Given this list of marker genes PIGG, PIGM, PIGF, PIGH, PIGP, PIGY, PIGL, PIGV, PIGX, PIGA, PIGQ, PIGW, PIGN, PIGB, PIGO, DPM2, PIGC, PIGZ, here is a description of the gene set: Glycosylphosphatidyl inositol (GPI) acts as a membrane anchor for many cell surface proteins. GPI is synthesized in the endoplasmic reticulum. In humans, a single pathway consisting of nine reactions appears to be responsible for the synthesis of the major GPI species involved in membrane protein anchoring. This pathway is shown in the figure. Two additional reactions, not shown, allow the synthesis of variant forms of GPI, one with an additional mannose residue and one with an additional ethanolamine. These variant GPI molecules may be used for tissue-specific protein modifications, or may function independently.<p>The steps of GPI synthesis were first identified by isolating large numbers of mutant cell lines that had lost the ability to express GPI anchored proteins on their surfaces. Somatic cell hybrid analyses of these lines allowed the definition of complementation groups corresponding to distinct mutated genes, and cDNAs corresponding to normal forms of these genes were identified on the basis of their abilities to restore normal cell surface protein expression in mutant cells. Co-precipitation experiments with tagged cloned proteins have allowed the identification of additional proteins involved in GPI anchor biosynthesis. species: Homo sapiens Reactome Pathway: Synthesis of glycosylphosphatidylinositol (GPI) part of: Post-translational modification: synthesis of GPI-anchored proteins